The following is a description of a gene set: Human Gene Set: GOBP_POSITIVE_REGULATION_OF_MYOBLAST_DIFFERENTIATION studied in species Homo sapiens Any process that activates or increases the frequency, rate or extent of myoblast differentiation. A myoblast is a mononucleate cell type that, by fusion with other myoblasts, gives rise to the myotubes that eventually develop into skeletal muscle fibers., and this is the list of marker genes: SMYD1, ZFHX3, CXCL9, BOC, SMARCD3, SMARCA2, ARID1A, MYOG, KAT5, MAPK14, MIR199A1, BTG1, MYF5, SMARCD1, SMARCB1, ACTL6B, MAP3K5, TNFSF14, HIF1AN, PLCB1, SMARCA4, PBRM1, ACTB, BRD7, RIPOR2, DPF3, SMARCE1, CCL8, RANBP3L, ACTL6A, PHF10, CSRP3, MUSTN1, SMARCC1, AKIRIN1, XKR8, SOX4, MYOD1, SMARCD2, MEF2C, RBM24, SMARCC2, ARID2, IGFBP3, LRRC8A (NCBI Gene Id 56262), MYF6, ARID1B